Given this list of marker genes CLCN3 (NCBI Gene Id 133073), P2RX7, SHANK3, ANO6, KCNMA1 (potassium calcium-activated channel subfamily M alpha 1), here is a description of the gene set: Human Gene Set: GOBP_NEGATIVE_REGULATION_OF_CELL_VOLUME studied in species Homo sapiens Any process that decreases cell volume.